Given this list of marker genes ERI2, MRPS22, CETN2, MDC1, TXN, IDH3B, STOML2, KCNK10, FECH, RHEB, TTLL1, GUCY1B1, ARL3, DESI2, BAHCC1, COMMD4, MFAP4, CEP43 (NCBI Gene Id 11116), INA, AAMDC, RAD51C, RBCK1, CSE1L, PTCRA (NCBI Gene Id 89959), EPB41L2, GART (phosphoribosylglycinamide formyltransferase, phosphoribosylglycinamide synthetase, phosphoribosylaminoimidazole synthetase), TNFSF4, NUP107, DPM3, TNFRSF21, CDK2AP1, CBFA2T3, EIF4A3, TUBG1, STN1, ECI1, TRO, HSD17B10, CLGN, DDX1, FBXO7, CHST12, MTX1, FAIM, GNL2, MZB1, GSE1, HEMK1, RFC2, SNRNP40, SLC29A1, TIMP2, BLNK (B cell linker), CPVL, PCCB, SORT1, MRM3, RAG1, TRAF3IP2, UTP3, GALNT2, SEC31B, SPAG1, RUVBL1, HMGN5, JCHAIN, TMEM177, RAPGEF5, RRAS2, MRPS18A, JAM3, CREB3L2, VANGL1, RPL26L1, CIB2, ALCAM, RNF130, RNASEH2A, PGD, ABCC1, CXCR4, STMN1, CA6, CEP70, SEH1L, HADH, TXNRD1, EIF2B2, BAG5, NUBPL, KCNK15-AS1, MAD2L1, NOTCH1, CD79A, GNG11, BUB1, RAP1GAP2, ADK, ARPP21, UCK2, HLA-DRB1, DAPK1, CTSG, ZMYM3, CHCHD3, ALDH7A1, NHP2, MYC, TRIP6 (NCBI Gene Id 96624), EXOSC4, OR7E47P, GFI1, ZNF112, MLLT11, NQO1, RUBCNL, POLE3, CFH, PSMD4, AURKB, ETS2, GAS7, MAP1A, TFDP2, TMEM131L, TTF2, MRPL16 (mitochondrial ribosomal protein L16), NTHL1, FXYD2, ARHGAP19, CD1B, UBE2E1, CSNK2B, REXO2, UQCRFS1, ESD, SETBP1, GRK3, LCMT1, PRKCA, PLS3, CAT, SLC27A5, ZNF282, GCHFR, GUCY1A1, RAB13, PRMT5, PSMC1, NARS2 (asparaginyl-tRNA synthetase 2, mitochondrial), SYK, KCTD3, PREX2, SCNN1B, NEIL3, PSMB3, ARMCX1, PACSIN2, ANXA4, AHI1, PLCG2, IFT46 (intraflagellar transport 46), PLK4, ZNF254, RTRAF, TSHR, ACAT2, COPS3, MRPS12 (mitochondrial ribosomal protein S12), DNAJC12, EAF2, BAZ2B, CLTA, PEX5, CTNNAL1, RMI1, TSPAN7, PRUNE2, LETM1, TK2, CD24, KCTD9, DTYMK, EIF4H, HDGF, POLR2I, RAG2, EFCAB11, GNA15, TCEAL9, MPC2, DNAJB6, LDLRAD4, SCRN1, PLPP3, TCEA2, GATB, STK3, MYB, here is a description of the gene set: Human Gene Set: GSE1460_INTRATHYMIC_T_PROGENITOR_VS_CD4_THYMOCYTE_UP from publication Lee MS, Hanspers K, Barker CS, Korn AP, McCune JM (PMID 15210650) species: Homo sapiens Subpopulations of human fetal thymocyte and circulating naïve T cells were obtained through FACS sorting, including CD3-CD4+CD8- intrathymic T progenitor cells (ITTP), CD3intCD4+CD8+ \double positive\ thymocytes (DP), CD3highCD4+CD8- \single positive\ thymocytes (SP4), CD3+CD4+CD8-CD45RA+CD62L+ naive T cells from cord blood (CB4+), and CD3+CD4+CD8-CD45RA+CD62L+ naive T cells from adult blood (AB4+). Genes up-regulated in comparison of intrathymic T progenitor cells (ITTP) versus CD4 thymocytes.